The following is a description of a gene set: Human Gene Set: GOBP_IMP_BIOSYNTHETIC_PROCESS The chemical reactions and pathways resulting in the formation of IMP, inosine monophosphate. species: Homo sapiens, and this is the list of marker genes: ADSL, PFAS, HPRT1, PPAT, AMPD3, ATIC, AMPD1, AMPD2, PAICS, GART, APRT